The following is a description of a gene set: studied in species Homo sapiens Human Gene Set: HP_ALBUMINURIA Increased concentration of albumin in the urine. Albuminuria, and this is the list of marker genes: PKD1, GANAB, GCK, ALG5 (NCBI Gene Id 29880), AMN, COL4A3, PKD2, GALT, MIA3, PDX1, KCNJ11, PEX1, ABCC8, DNAJB11, IER3IP1, BICC1, LMNA, CUBN, INS, IFT140, ALG9, SLC37A4, STAT3